Given this list of marker genes NUP214, CEP83, DNTTIP2, STS, PPP1R16B, GRPEL1, RNASET2, FCER1A, SLC16A5, CX3CR1, CD83, APLP2, SMARCC1, CCNG2, MX2, DAPP1, RUNX3, CCNL1, NOTCH2, EGLN3, SYF2, IMPA2, FYB1, SDR39U1, ETS2, HLA-E, MAN2A2, TLE4, ARHGEF40 (Rho guanine nucleotide exchange factor 40), SON, MPRIP, NEK3, BTG1, LMNB1, PLIN2, TRAF5, SFPQ, DDIT4, ZNF185, MIS18BP1, RPL22, BCOR, RASGRP2, RUBCNL, NDE1, TBCB, CD300A, IGFBP7, PRKCB, MYD88, DENND3, MSRB2, MS4A6A, RAP1GAP2, NFATC2IP, QPRT, CSNK1E, ITPK1, MEF2C, ZDHHC18, ADAM8, TMX4, PECAM1, CASP1, PGS1, HLA-DQA1, NLRP3, AOAH, TTN (titin), ITGA4, LILRB2, HDAC9, SLC2A3, DPYSL2, DPEP2, RAB11FIP1, MARCKSL1, RO60, MYO15B, RNF138, PLEKHA5, PELI1, FYN, SNHG32, NEDD9, ADAM19, CD14, CELF2, SLC7A7, IRAK3, METTL9, KLF10, TUBA4A, SH3BP5, NAMPT, TRADD, IRAG2, F2RL1, PHACTR1, RABGAP1, C5AR1, SPTLC2, EREG, VCAN, HNRNPA1, CALML4, LTB4R, CD86, SETD1B, S100A9, RGS2, NME3, MAFB, LILRA2, LRRK1, AIF1, HBEGF, SMAD3, EGR1, RPS4XP2, CRIP1, RSAD2, CACNA2D3, NKTR, LTA4H, PLAAT4, GALC, ICAM3, HERPUD1, DECR1, CHPT1 (choline phosphotransferase 1), ALOX5, TRIT1, SELL, PLCL2, SIK3, NR4A2, ARGLU1, RNASE4 (ribonuclease A family member 4), CD163, TREM1, PTGER2, RERE, NREP, CYTH1, IQGAP2, SCN11A, WNT5B, FCAR, AMPD2, S100A12, LMO2, CD48 (NCBI Gene Id 962), CDKN1C, VMP1, GTF3A, FPR1, TCF7L2, MS4A4A, SMIM7, PNP, NRG1, PID1, ZFAND5, CCNI, IL13RA1, ARHGEF6, ZNF395, NCOA1, NARF, MAP3K14, FKBP1B, FBXL5, NINJ2, AMY1A, TSEN34, PLSCR1, STK17B, SPINT2, MAP3K6, KIF2A, SIGIRR, CXCR4, GADD45B, FNBP1, DUSP6, DEPTOR, TNK2 (tyrosine kinase non receptor 2), PDIA5, TMEM131L, MAPRE2, ACP3, ATRX (NCBI Gene Id 6475), CCDC69, FCHSD2, MCL1, HOMER2, HDDC2, PPM1F, TIA1 (NCBI Gene Id 7072), NET1, MED13L, CFP, CIRBP, ST6GAL1 (NCBI Gene Id 6480), PLAC8, SPOCK1, MAP4K4, PTP4A3, MAP4K1, CD55, IFITM2, FCN1, IER5, ZFP36, GAS6, HADHA, CD52, ANP32A, CNPY3 (NCBI Gene Id 10695), HEBP2, RPL28, ACADVL, BATF3, RGCC, ZHX2, CFD, IFITM3P7, SEPTIN9, CDKN1A, EIF2AK2, SORL1, MICAL1, SP110, LPP, SCO2, ICAM2, LY86, ITGAL, PRKRIP1, here is a description of the gene set: Several hematopoietic growth factors, including interleukin-10 (IL-10) and transforming growth factor-beta1 (TGF-beta1), promote the differentiation of tolerogenic dendritic cells (DCs). Hepatocyte growth factor (HGF) is a pleiotropic cytokine whose effects on human DC differentiation and function have not been investigated. Monocytes cultured with HGF (HGFMo) differentiated into accessory cells with DC-like morphology, released low amounts of IL-12p70 and up-regulated IL-10 both at the mRNA and at the protein level. Upon activation with HGFMo, allogeneic CD4+CD25- T cells expressed the T regulatory (Treg)-associated transcription factor FoxP3, proliferated poorly, and released high levels of IL-10. Interestingly, blockade of surface immunoglobulin-like transcript 3 (ILT3) on HGFMo or neutralization of secreted IL-10 translated into partial restoration of T-cell proliferation. Secondary stimulation of HGFMo-primed CD4+ T cells with immunogenic DCs differentiated with granulocyte-macrophage colony-stimulating factor (GM-CSF) and IL-4 from monocytes of the same donor resulted in measurable T-cell proliferation. HGFMo-primed CD4+ T cells significantly inhibited the proliferation of naive CD4+CD25- T cells in a cell-contact-dependent manner. Finally, DNA microarray analysis revealed a unique gene-expression profile of HGF-activated monocytes. Collectively, our findings point to a novel role for HGF in the regulation of monocyte/DC functions that might be exploited therapeutically. studied in species Homo sapiens from publication Rutella S, Bonanno G, Procoli A, Mariotti A, de Ritis DG, Curti A, Danese S, Pessina G, Pandolfi S, Natoni F, Di Febo A, Scambia G, Manfredini R, Salati S, Ferrari S, Pierelli L, Leone G, Lemoli RM (PMID 16527888) Genes down-regulated in peripheral blood monocytes by HGF. Human Gene Set: RUTELLA_RESPONSE_TO_HGF_DN